Given this list of marker genes ADORA3, PSIP1, PI4KB, NDUFAF3, NPNT, PACC1, VGLL4, TAOK2, IL4I1, PCDHGA5, CYTOR (cytoskeleton regulator RNA), CSF1, PTHLH, FAM241A, MAX, IKZF2, PTPN7, PTPRH, OTP, RUFY1, TBC1D10C, RAC2, C1orf162, CORO1C, HOXA1, REST, ATP5PD, CCR7, LINC03040, TRPV2, IRF2BPL, TOB2, TAX1BP3, LANCL3, ACSBG1, ADAM15, PBX4, PIK3AP1, G6PC3, ACOT7, PLXNC1, TTC23, RORC, ORMDL3, TNFSF13, NOSTRIN, SLC43A2, LIF, STARD13, APOBR, ARHGAP30, SYTL1, HOXC6, KCNQ1 (NCBI Gene Id 3784), EVA1B, GAL3ST3, RASGRP3, UXT, ASPHD1, ITGB7 (integrin subunit beta 7), ADAP1, SH2D3C, FOXO4, EFNA1, VIP, PCSK5, INPP5F, ACVRL1, ITGA11, RASIP1, SLC12A4, SLC1A5, SCAF8, KIFC3, WASF2, S100A10 (S100 calcium binding protein A10), PLAGL2, ERBB3, SIPA1, TCIRG1, VASN, HOXB8, PABPC1, POC1B, SPECC1, SSBP4, SIK3 (NCBI Gene Id 80236), TCF12, DMP1, ICAM2, MUC13, SYT7, TRMT1L, PRICKLE1, MLLT10, AR, LRRFIP1, NIPBL, BRAF, LUC7L (LUC7 like), KCNQ5, FAM241B, ABI1, ESM1, PPP1R14C, TNFSF11 (NCBI Gene Id 8600), RERG, FOXA1, RAB2B, ANP32A, FYN, LGALS4, GCK, MEIS2, NAV2 (neuron navigator 2), RORA, KALRN, PCDHAC2, ANGPT1, CACNA1D, PIK3CG, ADORA1, BMP5, CPEB4, CLIC1, BRD9, TGM7, ZFAND3, ANGPTL1, EVX1, SEC16B, MTPN, POFUT1, VASP, PCDH9, CHMP5, CD5 (NCBI Gene Id 921), CBFA2T3, WNT6, ATP13A2, NUFIP2, RINL, CA4, DPP8, ZNF384, NLGN3, PKN1, DCAF1, FBXL20, RBMS3, VSIG2, EID1, STAP1, TRIP13, PTPN6 (NCBI Gene Id 5777), ASB7, DDX23, FMNL1, CXXC5, LINS1, TLL1, NAV1, FBXO11, RAB20, NDFIP1, ICA1, PCDH17 (NCBI Gene Id 27253), WNT3, ASB2 (ankyrin repeat and SOCS box containing 2), TLN1, LINC00525, GALNT4, ETF1, FLNC, GNGT2, PLVAP, DOP1A, LCP2, ELN, CYTH4, TPM3, TFB2M, LINC01138, SMOX (NCBI Gene Id 54498), PLA2G4A, ADD3, WDFY3-AS2, MGAT4C, MAP2K1, YWHAZ, SH3RF1, DNAI4, IL13, NCAM1, DOK2, TIMELESS, MAP1S, PI4K2A (phosphatidylinositol 4-kinase type 2 alpha), CSF3, SAMSN1, TNF, EVI2B, CLSTN3, SOST, CEBPG, BNC2, S100G, SEPTIN1, VAV1, TWIST1, HHEX, GGNBP2, ACSL4, STAT5A, CXCR3, GPR107, C1QTNF5, SRC, TBCC, OSER1, FGF14, IL17C, NCEH1, SMS, PTK7, DHH, C1orf122, BAG1, NINJ2, KIRREL3-AS3, OARD1, CTBP2, XIAP, PLAT, E2F3, PPP4R3B, HTR3B, TBC1D10B, CALHM2, PML, KCNMB3, PUS7L, TNFSF14, GPN2, CKB, GPAT3, POLD3, ARFGEF1, PDLIM2, SNCG, LRRC28, LRRC32, TFAP4, DCANP1, SEC14L2, SRP72, RGS12, VIM (NCBI Gene Id 7431), YRDC, DLX4, HNRNPUL1, IRF8, NRP1, MIRLET7BHG, MMP9, OSBPL7, NHERF1, CYB5R3, TMC3, CD37, DNMT3A, IER5L, DLAT, ST8SIA4, HYAL3, FAM110A, PSEN1, CNOT6L, ARL6IP6, USP46, NFYA, EMCN, ANGPT2, PLCD1, PTGS1, IRAG2, SPATA6, ANGPTL2, RBP5 (NCBI Gene Id 83758), CUEDC1, TMEM178A, ZNF502, CTNND1, UBALD2, CDK8, ZNF532, CCDC68, FRMD8, TRIM63, ITPRIPL1, GLT8D2, GPR162, POLD4 (DNA polymerase delta 4, accessory subunit), SKAP1, MTMR12, WIPI2, MARK3, DLC1, LTC4S, ABI3, ATPAF2, CMYA5, PTBP3, MOB3C, SPRED2, ADCY4, PLD3, EVA1A, ADGRG1, RALA, LTB4R, MAGED1, ARFGAP2, MPO, ZNF777, RBM6, SH3TC1, CLNK (NCBI Gene Id 116449), ARHGEF4, NDN, FAM81A, CCN1, SLC39A14, P2RY10, TBC1D8, VSIG10, HMGN3, CAMK2B, MIER1, HOXC4, CNST, EIF4EBP1, PARP8, CREB5, PCDH10, ALDOA, SCG3, FAT1, PRSS27, DALRD3, PTAFR, IL17RE, ANKRD28, WNT9B, MATN3, ZBTB14, HAPLN1, TNK1, HTR2B, CCDC88B, RLIM, ELMO1, CDX2, ZNFX1, WDFY3, ATP1B3, HR, LTA, SLC9B2 (solute carrier family 9 member B2), ROCK1 (Rho associated coiled-coil containing protein kinase 1), CDC5L, RHOJ, TYROBP, CAPN3, ITPR2, NEURL2, SPI1 (NCBI Gene Id 6688), GPR85, SCRT2, CD200R1, GID4, SYNRG, CD101, YWHAQ, CD79B, KRT23, SEMA6B (NCBI Gene Id 56991), PROSER3, SLA2, PAX8, TREML2, SECISBP2L, CACNA1G, KLHL3, BIN2, TMOD3, GPR137B, GPR173, PTPRCAP, UNC13D, PITX2, PFKFB4, AHR, NR3C2, PIK3R3, KIRREL3, SRRM1, PTGDR2, VDAC2, MSH5, MTX2, BCLAF3, TMEM185A, LSM12, RTP1, FCRLA, MMRN2, ZBTB7A, FAM3D, PTGIR, GRIN2B, NTS, TREX2, EGLN2, DMTF1, GALE, TIE1, TPM2, ID3, RAB5C, ARHGEF15, DHX30, ZFYVE1, POU2AF1, LAMP2, NPTN, AGAP2, LYL1, WNT5A, CAMK1D, PSD3, LEMD1, RALY, BCL2, RILPL1, FGF20, TFE3, MXD4, EMC6, SOX5 (NCBI Gene Id 6660), MSX1, TLR4, SLC16A6, HPRT1, PAX6, PPRC1, MAP4K2, PTPRJ, ELOVL6, CEP135, GLRX5, IMPDH1, CREB3, ORC4, NFAT5 (nuclear factor of activated T cells 5), TMEM204, HAUS3, NCLN, GIMAP4, TMEM59L, EMX2, PRDM5, CEBPE, STAB1, GAREM1, FGD2, ITGA2B, ESRRA, STC2, NCKAP1L, OVOL2, DOCK11, RAB39A, SLC7A1, PPP1CC, RPL28, NAA80, RXFP4, CHD2, MR1, LYN, NKX2-2, TACR1, SLC41A1, PTPN22, PLCB2, CYP1B1-AS1, IRAK4, CNNM1, TMPRSS11D, CTSA, SWT1, RAPGEF1, ETV6 (NCBI Gene Id 4348), PATZ1, CFAP251, MAP9, CSF2, ARAP1, GIT2, IL12B, TMPO, CDV3, EFNB3, ITGAL, here is a description of the gene set: studied in species Homo sapiens from publication Xie X, Lu J, Kulbokas EJ, Golub TR, Mootha V, Lindblad-Toh K, Lander ES, Kellis M (PMID 15735639) Genes having at least one occurrence of the highly conserved motif M50 RGAGGAARY in the regions spanning 4 kb centered on their transcription starting sites. This matches the SPI1 transcription factor binding site V$PU1_Q6 (v7.4 TRANSFAC). Human Gene Set: RGAGGAARY_PU1_Q6 Comprehensive identification of all functional elements encoded in the human genome is a fundamental need in biomedical research. Here, we present a comparative analysis of the human, mouse, rat and dog genomes to create a systematic catalogue of common regulatory motifs in promoters and 3' untranslated regions (3' UTRs). The promoter analysis yields 174 candidate motifs, including most previously known transcription-factor binding sites and 105 new motifs. The 3'-UTR analysis yields 106 motifs likely to be involved in post-transcriptional regulation. Nearly one-half are associated with microRNAs (miRNAs), leading to the discovery of many new miRNA genes and their likely target genes. Our results suggest that previous estimates of the number of human miRNA genes were low, and that miRNAs regulate at least 20% of human genes. The overall results provide a systematic view of gene regulation in the human, which will be refined as additional mammalian genomes become available.